The following is a description of a gene set: Reactome Pathway: Gluconeogenesis species: Mus musculus part of: Glucose metabolism This event has been computationally inferred from an event that has been demonstrated in another species.<p>The inference is based on the homology mapping from PANTHER. Briefly, reactions for which all involved PhysicalEntities (in input, output and catalyst) have a mapped orthologue/paralogue (for complexes at least 75% of components must have a mapping) are inferred to the other species. electronically inferred by orthology from the curated human pathway, and this is the list of marker genes: Aldob, Pgam2, Eno4, Tpi1, Slc37a2, G6pc3 (NCBI Gene Id 68401), Slc37a1, Gapdhs, Pck2, G6pc1, Eno3, G6pc2, Slc37a4, Pgk2, Fbp2, Aldoa